The following is a description of a gene set: from publication Gavin MA, Rasmussen JP, Fontenot JD, Vasta V, Manganiello VC, Beavo JA, Rudensky AY (PMID 17220874) Regulatory CD4+ T cells (Tr cells), the development of which is critically dependent on X-linked transcription factor Foxp3 (forkhead box P3), prevent self-destructive immune responses. Despite its important role, molecular and functional features conferred by Foxp3 to Tr precursor cells remain unknown. It has been suggested that Foxp3 expression is required for both survival of Tr precursors as well as their inability to produce interleukin (IL)-2 and independently proliferate after T-cell-receptor engagement, raising the possibility that such 'anergy' and Tr suppressive capacity are intimately linked. Here we show, by dissociating Foxp3-dependent features from those induced by the signals preceding and promoting its expression in mice, that the latter signals include several functional and transcriptional hallmarks of Tr cells. Although its function is required for Tr cell suppressor activity, Foxp3 to a large extent amplifies and fixes pre-established molecular features of Tr cells, including anergy and dependence on paracrine IL-2. Furthermore, Foxp3 solidifies Tr cell lineage stability through modification of cell surface and signalling molecules, resulting in adaptation to the signals required to induce and maintain Tr cells. This adaptation includes Foxp3-dependent repression of cyclic nucleotide phosphodiesterase 3B, affecting genes responsible for Tr cell homeostasis. Cluster P6 of genes with similar expression profiles in peripheral T lymphocytes after FOXP3 loss of function (LOF). species: Mus musculus Human Gene Set: GAVIN_FOXP3_TARGETS_CLUSTER_P6, and this is the list of marker genes: ST8SIA6, CST7, SPC24, CLSPN, RPL17, GINS2, CENPE, CDCA8, AURKB, H3C15, PCLAF, PLK1, TNFRSF9, CKS1B, ACOT7, RRM2, NRN1, CDC20 (NCBI Gene Id 991), FBXW8, NCAPG, AURKA, IRF8, SLC25A53, STARD10, CCNB1, TKTL1, BIRC5, MTMR7, BMP7, SNX9, GEMIN8, CCNA2, CENPF, CHDH, AR, NUSAP1, BUB1, CDCA5, RAD51, BUB1B, NEDD4, TPX2, KIF20A, CDCA3, ABHD4, CDK1, IFI44, FIGNL1, UNC119, CEP55, TGFBR2 (transforming growth factor beta receptor 2), CCR2, ICAM1, CYSLTR2, DCTD, TYMS, H1-2, NCAPG2, RAD54L, ZCCHC18, ALAD, PDCD1LG2 (programmed cell death 1 ligand 2), IGF2BP3, ABCB1, SLC39A4, SPAG5, NEK2, ATF6, IL17RB (interleukin 17 receptor B), CCNB2, CMPK2, MYO1F, RASGRP2, MCM10, VARS2, IL12RB1, SPC25, TK1, HMMR, KSR1, CENPK, GZMB, ODC1 (ornithine decarboxylase 1), NUF2, PBK, KIF2C, MMS22L, TMEM38B, LGALS3, SERPINA3, TPI1, ASPM, EBI3